Given this list of marker genes ATF4, BAG1, FGFR1, LBH, CNN1, PKIG, RPF2, MAP3K7CL, EIF2S1, MT2A, EIF4E, EIF5, TAGLN, FXYD1, H2AZ1, H3-3B, TUBA1C, RAD23A, PHLDA1, CYTOR, OPA3, COL18A1, TNFRSF1A, NAA50, LITAF, MRPL32, AKAP13, SELENOS, MRPL18, MAFF, CALM2 (NCBI Gene Id 805), ARID5A, SELENOM, LGALS1, H2AJ, CD59, SLC25A5, ACTN1, GNL3, CTSL, MYLK, HNRNPA2B1, HNRNPM, NR1H2, HSP90AB1 (heat shock protein 90 alpha family class B member 1), YBX1, C11orf96, LIMS1, HSP90AA1, MIR22HG, HSPE1, CSRNP1, UBE2D3, HES4 (hes family bHLH transcription factor 4), CHD1, ARID5B (NCBI Gene Id 84159), ZNF331, HSPA1A, CD9 (NCBI Gene Id 928), EIF4A1, TUBA1B, IGFBP7, PITPNB, MRPS6, EDNRA, IQCG, BCAM, FKBP4, EIF4A3, ADAMTS4, HNRNPH1, MRTO4, PEA15, UBA2, SFPQ, CDKN1A, CCT6A, PHLDA2 (NCBI Gene Id 7262), IER3, TM4SF1 (transmembrane 4 L six family member 1), ISYNA1, DSTN, NOP16, SRRM2, ATF3, SBDS, EFHD1, TUBB4B, EEF2, MYL9 (NCBI Gene Id 10398), EPAS1, RASSF1, CSRP2, HIPK2, CCNI, ATP1B3, LMNA, CYCS, PDK4, NUDT4, BAG3, TSSC4, TSC22D1, PTN, FRZB, MTHFD2, HSPD1, KCTD20, RAN, MIR4435-2HG, CRISPLD2, IFITM3, MAP1LC3A, PLEKHO1 (pleckstrin homology domain containing O1), CD151, STOM, COQ10B, CCT3, HSPA9, NUDC, OAZ2, STIP1, CSRP1, PTP4A3, YBX3 (NCBI Gene Id 8531), HSPA8, HSPB1, SOD1, STAT3, GPX3, MT1A, GLA, TNFRSF12A, MAP1B, EMP2, CACYBP, LRCH3, BGN, AHSA1, NDUFA4L2, TINAGL1, ISG15, DDX21, RPL36AL, LDHA, PNO1, DNAJB9, TCP1, MALAT1, PRDX1, KDM6B, NDRG2 (NCBI Gene Id 57447), UBE2S, PGF, DNAJB1, AXL, GABARAPL1, CYSTM1, WDR43, OAT, ATG101, ILF2, ZFHX3, VASN, TPM1, MYL6, SLC3A2, CREM, MAT2A, RGS5, SQSTM1, CRYAB (NCBI Gene Id 1410), PRKAR1A, PLEKHA4, DNTTIP2, CD44, GEM, TPM2, CD63, CPE, FAU, HSPB8, NR4A1, CALR, MAP2K3, MSN, COL4A1, MYH11, PDLIM5, HSPA2, SLC25A3, ADIRF, ADAMTS1, SOD3, NEAT1, CLIC4, AOPEP, ETS2, SELENOK, DUSP14, DNAJB6, CALM1, CCDC3, CCT5, MT-ND2 (NCBI Gene Id 4536), RRS1, PDGFRB, TAF7, MFGE8, EIF1, MT-ND1, CRY1, TIMP3, ACTA2, XBP1, A2M, GJA4, PTGES3, FXYD6, ROCK1, AKAP12, GADD45B, ZBTB38, SERPINH1, HNRNPF, CAV1, NR4A3, GNL2, TMEM165, PNRC1, DEGS1, here is a description of the gene set: The clusters of smooth muscle cells (CL14, CL17) also showed features of growth and remodeling: many DEGs of CL17 (such as CRYAB, GJA4) were involved in regulation of immune response and apoptosis, whereas DEGs of CL14 (such as ACTA2, PLN, ADIRF, and MYH11) associated with mature smooth muscle cells (Fig. 3e-g). species: Homo sapiens Human Gene Set: FAN_OVARY_CL17_PUTATIVE_APOPTOTIC_SMOOTH_MUSCLE_CELL from publication Fan X, Bialecka M, Moustakas I, Lam E, Torrens-Juaneda V, Borggreven NV, Trouw L, Louwe LA, Pilgram GSK, Mei H, van der Westerlaken L, Chuva de Sousa Lopes SM (PMID 31320652)